Given this list of marker genes MUC16, MUC13, MUC4, C1GALT1C1, C1GALT1, MUC5AC, MUCL1, MUC5B, MUC15, MUC21, MUC1, MUC6, MUC12, MUC7 (NCBI Gene Id 93297), MUC20, MUC17, MUC3A, here is a description of the gene set: studied in species Homo sapiens Human Gene Set: REACTOME_DEFECTIVE_C1GALT1C1_CAUSES_TNPS Defective C1GALT1C1 causes TNPS